The following is a description of a gene set: from publication Lund R, Aittokallio T, Nevalainen O, Lahesmaa R (PMID 14607935) Genes down-regulated in CD4 T cells: untreated (0h) versus activated by anti-CD3 and anti-CD28 and then stimulated by IL-12 (6h). Human Gene Set: GSE2770_UNTREATED_VS_IL12_TREATED_ACT_CD4_TCELL_6H_DN Th1 and Th2 cells arise from a common precursor cell in response to triggering through the TCR and cytokine receptors for IL-12 or IL-4. This leads to activation of complex signaling pathways, which are not known in detail. Disturbances in the balance between type 1 and type 2 responses can lead to certain immune-mediated diseases. Thus, it is important to understand how Th1 and Th2 cells are generated. To clarify the mechanisms as to how IL-12 and IL-4 induce Th1 and Th2 differentiation and how TGF-beta can inhibit this process, we have used oligonucleotide arrays to examine the early polarization of Th1 and Th2 cells in the presence and absence of TGF-beta after 0, 2, 6 and 48 hours of polarization. species: Homo sapiens, and this is the list of marker genes: RXRA, C1QBP, GAST, CACNB2, MAN1A2, RPS27L, CDC42BPB, ACTR6, CASKIN2, MYCL, NDUFV3, CCDC184, ELMO3, CDC14B, SERPINF1, DGKK, PSMD12, MRPS12, DHRSX, C5orf24, FGF13, FGB, VPS37C, EIF3J, SCARB1, RPS10, LRRC3, GALNT10, GYS1, IRF5, SYNRG, UBD, CCNYL1, SPATS2L (NCBI Gene Id 26010), ATG4B, FZR1, SLC35F5, CDH13, RNASET2 (NCBI Gene Id 8635), GARS1, FCF1, PTGR3, MALSU1, CLCN6, RPS6KL1, BPHL, CORO7, AP1S3, ADGRL4, GOT2, CYTH1, DYRK3, IL15, RASGRP3, COL27A1, PTRHD1, CALR, C1orf53, DPAGT1, CACYBP, PRDM15, FRMD4B, NSMCE1, CHIC2, PSMD3, SRGAP2, CES3, ASAH2, FSTL4, NET1, CDKN1A, WNT7A, ASB11, HOXD13, TOMM70 (NCBI Gene Id 9868), SLC35A4, SPO11, CCDC120, HEXD, RTL8C, H2AX, PLPP2, SCRN1, DIS3L, MYO9A, GRAMD1C, CAPN15, CARD19, ESYT2, UQCRB, MYO6, ELOVL6, GRAMD2B (NCBI Gene Id 65983), WDR91, ORMDL2, FZD7, SLCO1A2, CPNE3, AHR, ADORA2A, CTDP1, AFF1, WASHC5, CGREF1, TWNK, LOXL3 (NCBI Gene Id 84695), TRIM28, SPTBN1, PROKR2, CMC2, OSTC, ALDOA, ADAM8, CD200 (NCBI Gene Id 4345), ANXA1, TAX1BP3, GNA15, SLC22A23, PRKRA, RNF169, PID1 (NCBI Gene Id 55022), TNFAIP2, HOXC13, PEDS1, TAP2, RNMT, STRADB, GPT2, PKIB, LRRC28, SEPSECS, CHRNA4, SHC4, MTMR14, KRTAP8-1, ALDH4A1, PACS2, ACE2, ARHGAP5, FASTKD1, WHAMM, TMBIM4, ST13 (ST13 Hsp70 interacting protein), GCAT, TM4SF5, PWWP2B, ATP8A1, TXNL1, DAAM1, MAPK8IP2, COL26A1, GTF3C6, NAGA, RAB2A, TNK1, C3orf70, MFSD14A, EPSTI1, APRT, ZFHX3, DIPK2A, CTDSP2, PREP, SIK2, GLRX3, MVB12A, TMEM88, CCDC107, STRBP, DHX32, HAS1, SPACA4, PHB2, VAX2, MTHFR, CLIC6, KBTBD3, AANAT, ARSI, GPR65, RASSF9 (NCBI Gene Id 9182), TAP1, PI4K2B (NCBI Gene Id 55300), BAZ1A, CLEC12B, PPA1, KLHL6, PPP2R3C, TAF5L, COG2, CRELD2, MIP, SEC24D, PI4K2A, MLX, ASAP2, SIL1, PKP4, SPATA6, FNDC5